The following is a description of a gene set: Any process that stops, prevents or reduces the frequency, rate or extent of neuroinflammatory response. Mouse Gene Set: GOBP_NEGATIVE_REGULATION_OF_NEUROINFLAMMATORY_RESPONSE species: Mus musculus, and this is the list of marker genes: Trem2, Tafa3, Cd200l2, Igf1, Cd200, Sbno1 (NCBI Gene Id 272223), Pparg, Grn, Tnfrsf1b, Nr1d1, Ldlr, Cst7, Syt11, Cx3cl1, Ifnb1, Cd200l1, Cd200r1